The following is a description of a gene set: Human Gene Set: HP_ABNORMALITY_OF_PRENATAL_DEVELOPMENT_OR_BIRTH Abnormality of prenatal development or birth species: Homo sapiens An abnormality of the fetus or the birth of the fetus, excluding structural abnormalities., and this is the list of marker genes: DHCR7, CC2D2A, BUB1, BUB3, PLPBP, RAC2, CLCNKA, SHOC2 (SHOC2 leucine rich repeat scaffold protein), NIPBL, LAGE3, IFIH1, SMC3, TCTN1, LMNA, KIAA0586, WNT9B, SHPK, SMO, PPP1R13L, PUF60, ARSB, TSHR, ITGA8, EPB41, TCF4 (transcription factor 4), NDUFB10, PEX6, GATA6, RSPRY1, CERT1, COL1A1, SMC1A, ANO1, LAMB2, MDM2, OPA1, CAPRIN1, LZTR1, AARS1, DOHH, SNRPN (NCBI Gene Id 6638), GRIN2D, SPTA1, STK11 (serine/threonine kinase 11), RBM10, FGFR1, RPL8, NUP107, CELF2, NDUFS6, CFH, FAS, RPS19 (ribosomal protein S19), CTCF, ABCB11 (NCBI Gene Id 8647), CDKN2A, STOX1, PTPN11, DNMT3A, LBR, TAF6 (NCBI Gene Id 6878), RAG2, B4GALT1, MYLK, GABRG2, POLR2A, CALM2, SNTA1, DCLRE1C, RAD51, DBR1, CNTNAP1, ACTL6B, SEMA3D, EXTL3, GTF2IRD1, GFPT1, IFT80, DDX6, BUB1B, PLVAP, NOTCH1, HOXD13, GTF2I, PEX16, BSND, ACTA1, HPS6, NAA10, KCNA2, COL5A1, MYCN, NDUFS8, FZD4, NCF1, NDUFV2, TFAM, GBE1, FANCL, CFL2, DST, SIX3, UQCRFS1, FANCF, FARSB, DPF2, SLC25A1, B3GLCT, ZBTB42, COX15, NALCN, EBF3, HSPG2, MCTP2, TRIP4, NRCAM, MRPS22, CDC42BPB, DLL4, ASH1L, FERMT1, MPLKIP, ATP6V1A, HCN1, PMM2, ERBB3, TSEN2, DPYSL5, CDK13, ARSL, NDUFS1, RRAS, CLCN3, KLHL40, KRAS, DNM1, CHRNG, KCNJ1, TRAIP, PRMT7, TBX4, GBA1, MCM10, CYFIP2, PPM1B, CNTN1, ZIC3, SKIC3, OSTM1, CHRND, SOX9, CRKL, FLII, RNF113A, RPS17, AP1S2, HIC1, SNUPN, VPS35L (VPS35 endosomal protein sorting factor like), RPGRIP1L, ALG12, PGAP2, MYMK, TRAK1, VPS37D, ITGA7, PLEC, RERE, ATP6V1B2, GATA1, EOGT, GATB, PARS2, ABCD1, PCDH12, ERGIC1, SCN4A (NCBI Gene Id 6329), ARPC5, SLC25A26, KANSL1, FGFR3, ANK2, KIF20A, KIF14, SLC17A5, SNORD116-1, AMER1, ASCC1, F8, DONSON, GPKOW, USP7, DEF6, DEAF1, PEX11B, CARS2 (cysteinyl-tRNA synthetase 2, mitochondrial), LTBP3, CBL (Cbl proto-oncogene), RPL11, CEP290, SMN1, DYNC2H1, FBXO28, CAPNS1, TRIM37, FOXF1, FBXO43, ZIC2, DHPS, RPL31, GABRB2, ITPR1, ATP7A, SCN8A, NDUFA11, IPO8, TMEM126B (NCBI Gene Id 95018), GYPC, SON, MT-ND3 (NCBI Gene Id 4537), CNOT1, NRTN, GON7, SCN10A, TOP6BL, SLC25A24, RASA2, SOS2, FDXR, NEK8, PHIP, SFTPC, RPS15A (ribosomal protein S15a), SLC3A1, FH, BCR, NDUFAF3, COL6A2, CLCN7, EBP (EBP cholestenol delta-isomerase), GRN, CHAT, ESAM, COL11A1, MGAT2, NDUFV1, WDR62, TMEM107, PADI6, TMEM67, RAB34, INPPL1, SCN4B, PEX26, METTL27, PTRH2, FKBP14, COX11, REN, SLC16A2, DNM2, COG8, NEU1, SFTPB, SMARCAL1, TMCO1, AKT2, ALG8, CYP11B1, NSD2, CD96, SLC9A3, GRIP1, RAI1, ADAT3, CCDC47, SCN5A, GTF2IRD2, PSAT1, PTPN23, MT-ND1, PAICS, ERCC2, DHDDS, HS2ST1, CALM1, RPL18, HSPA9, PACS1, NUBPL, YWHAE, COL6A1 (NCBI Gene Id 1291), TP53RK, ALG1, SELENON, DALRD3, KIT, HACD1, KCNC2, ZSWIM6, CREBBP, UBE2A, H19, PTCD3, NUP88, SQSTM1, TBX5 (T-box transcription factor 5), TBC1D24, PRPS1, FANCM, RPL35, NECTIN1, MRPS16, PIGY, SFXN4, SEMA3C, NLRP7, RTL1, RPS27, TMEM237, CCBE1, SPOP, NDP, IGHMBP2, CHEK1, STAG1, GALK1, TRPV4, UNC45B, TREM2, DPM2, CDKN1C, QRICH1, GNPTAB, MTM1, LMOD1, RPL26, CACNA2D1, RBCK1, MAGEL2, PREPL, NDUFAF1, RALGAPA1, MAMLD1, HBB (NCBI Gene Id 3043), CLCNKB, SLC6A5, ITGA2, NDUFS4, PEX10, SV2A, SCN3A (NCBI Gene Id 6328), MRAS, IGF2, NDUFB3, NUP133, GREB1L, MECOM, HNRNPK, COL5A2, RPL9, MADD, MYH3, HBA2, EIF5A, WASHC5, VPS33B, PEX3, TMEM70, KIDINS220, PIGQ, GNB2, AFF2, FLVCR2, PSEN1, ERCC4, RPL5, KCNE1, KRT1, POLR3A, SOX18, NPHP3, SCYL2, LETM1, RAPSN, MAGED2, NPC1, ALX4, SZT2, SPINT2, SLC35D1, SYT2, KBTBD13, MAP3K7, COL6A3, TP53, WNT4, REC114, HYMAI, WNT3, POMP, CRELD1, NDUFAF2, TCTN2, JUP, ADAMTS2, CYP11B2, ERBB2, MYL9, COL3A1, EEF1A2, NDUFB11, EMC10, ATAD3A, CHRNE, HIRA, FANCB, PEX5, DOK7, MDFIC (MyoD family inhibitor domain containing), CRPPA, FBXL4, B9D1 (NCBI Gene Id 27077), COL2A1, TP63, ABCA3, THSD1, DSP, SPTBN1, ATP1A3, TRIP13, COASY, AXIN1, VPS13B, XRCC2, MKS1, HNF1B, TPM3 (NCBI Gene Id 91191), RFC2, ALG14, SARS2, TRIP11, RYR1, GP1BA, STX5, PRRX1, SUFU, SEC24D, EDN3, MYPN, MAX, ALPK3, GRM7 (NCBI Gene Id 2917), MYT1L, QRSL1, MAPK1, ALDH1A2, RHD, ASNS, SMARCD2, PIEZO1, KDM3B, ZFP36L2 (ZFP36 ring finger protein like 2), SLC2A1, TSEN54, RNU4ATAC, COL12A1, DYNC2LI1, SNRPB, MTHFS, PIGV, RPL35A, MUSK, MT-ND2, YWHAG, PEX19, HDAC8, FANCA, SLC26A3, CRIPTO, GTF2E2, SEC61A1, CA2, ALB, ROBO1, SLC30A9 (NCBI Gene Id 10463), CPLX1, DZIP1L, TAF1, PHACTR1 (NCBI Gene Id 81705), OFD1, SF3B4, CALM3, RFWD3, MYD88, SPRED2, B9D2, CORIN, CAMKMT, FANCG, LYN, TOR1A, ABCA12 (ATP binding cassette subfamily A member 12), UBE2T, ASXL2 (NCBI Gene Id 55252), FANCC, NOS1AP, CDAN1, FLI1, AGT, ECE1, SOS1, TBL2, CILK1, GLB1, TPRKB, GPC3, TXNDC15, CHST3, RNU4-2, PAK2, LHX1, DNA2, SKIC2, MTMR14, EFEMP2, FBLN5 (fibulin 5), RPS7, THOC2 (NCBI Gene Id 57187), BICD2, NDUFS2, SLC12A1, FOXG1, SLC25A12, KCNJ6, GLRB, DYNC2I2, FASLG, IRF6, CDON, INVS, IL2RG, WNT7A, FGF20, KCNB1, RRAS2, PHGDH, RBPJ, VAMP1, ESCO2, ACE, FANCE, WDR81, BTG4, PACS2, FOXRED1, PIK3CA, PAX2, ABCC6, CLTC, DCLRE1B, LRP5, NTRK2, FAT4, PWAR1, NSD1, DTYMK, CEP57, TPM2, LEMD2, ITGA2B, KCNQ1, MMACHC, IL1RN, FUT8, STS, LAMA5, DISP1, MTO1, COPB2, AIMP1, TPI1, NLRP3, CLIP2, CHUK, ACTB, CLTCL1, RPL27, WARS2, BCL10, MAD2L2, NEXMIF, CSNK2A1, FGFR2, RAD51C, PEX2, TGM1, PLAGL1, PIGA, CRTAP, GATC, FOXE1, GP1BB, LIG4, PDHA1, GLDN, ADCY6, SMPD4, EXT2, TSR2, INTS11, BRAF, GLI3, NDUFA6, SCN1A, WBP4, FRA10AC1, TNNC2, IL7R, SLC5A7, TWIST2, PEX14, TLK2, RAF1 (NCBI Gene Id 5894), UBA1, OTUD5, MSX1, RAD21 (NCBI Gene Id 5885), PPP1CB, NDUFS7, SMG9, PAFAH1B1, ERF, KLHL41, RAC1, PLD1, TIMMDC1, UROS, INSR, ALDH7A1, RPS29, AVPR2, RNF31, DIS3L2, TRPV3, PIGS, RIPK4, NAA20, SLC13A5, CD46, CNKSR2, SLC31A1, VANGL2, MAPT, ZC4H2, CASP10, TSFM, MYF6, EIF4H, MCM4, PIGG, NEK1, SIN3A, GGPS1, COL1A2, LTBP4, LORICRIN, STX1A, RRAGC, CHEK2, IL2RB, HSD17B4, RIT1, YARS1, DNAJC30, DMPK, SOX17, CAV3, ELN, EXOSC9, NDN, TBCD, DOCK6, MEGF10, SLC18A3, HYLS1, MKRN3, WT1, ZBTB18, COMT, ITGB4, SYNE1, KCNE2, OCA2, FLG, PWRN1, RAP1B, RPS24, ALPL, KIF26A, TAOK1, PLAA, MAFB, RMRP, CALCRL, LIFR, DUOX2, GJB2, F2, RHCE, GABRA5, TARS1, CHRNA1, BNC2, ODC1, KANK2, RPGRIP1, ACY1, VCP, SMARCAD1, FXR1, ZFX, OTX2, SPTB, TBX1, ATP6V0A1, ITGB3, AGTR1, NDUFAF5, SLC25A46, BMPER, CRLS1, RYR3, C1QC, NEB, PEX12, FZR1, IBA57, DPH5, RPL10, SNORD115-1, COL13A1, KCNQ5, NFASC, CTBP1, IARS2 (NCBI Gene Id 55699), SLC26A2, PDX1, SYNJ1, ATP6V1E1, PLOD1, SEC24C, GLE1, TALDO1, NUP188, BUD23, GPC6, ATP1A2, NDUFS3, CCDC174, IARS1, SCARF2, SYNGAP1, VARS1, BRIP1, CACNA1C, TWIST1, TMEM106B, AP3B2, SLC27A4, FLT4, SLC6A9, GLI2, WDR35, ERCC5, MYH7, IGF1 (NCBI Gene Id 3479), RPS26, UROD, CHMP2B, C1QBP, COQ7, FRAS1, BRCA1, EGFR, FGF12, ARHGAP31, FANCD2, NDUFB9, CHD8, DYRK1A, DPAGT1, IQCN, TRPV6, KCNQ1OT1 (KCNQ1 opposite strand/antisense transcript 1), RAG1, TRAF7, ITGA6, SLX4, IL6ST, PGAP3, LONP1, DYNC2I1, ARVCF, CSPP1, CLPB, RPS28, HERC2, CPT2, CACNA1A, UBA5, PIGO, NUS1, SREBF1, FCSK, FILIP1, ZMPSTE24, ADNP, GABRA2, H4C3, EDNRB, MEI1, RET, POR, MED12, COL11A2, SLC35A2, FREM2, CCDC22 (NCBI Gene Id 28952), SLC38A3, MYO9A, PIGL (NCBI Gene Id 9487), MEG3, BAZ1B, LRPPRC (NCBI Gene Id 10303), KIF5C, RPS20, RASA1, YRDC, NDUFAF4, KMT2D, ERCC3, LMOD3, MYL2, NDUFAF8, WWOX, AKAP9, LIMK1, FLNB, ATP6V0A2, NEK9 (NCBI Gene Id 91754), PIGW, RPL15, CHRM3 (NCBI Gene Id 654136), CAMK2B, PEX1, ADGRG6, CFI, ASAH1, CDK19, GMPPB, PNPO, TTC7A (tetratricopeptide repeat domain 7A), NPAP1 (NCBI Gene Id 23742), TRAPPC12, GFRA1, ABCB4, MAP2K1 (mitogen-activated protein kinase kinase 1), SLC1A2, FCGR3B, IFT56, MAP2K2, AGGF1, CPSF3, CRB2, RSPO2, RNF2, LDHA, KHDC3L, HRAS, COX14, GUSB, JMJD1C, HMGA2, OSGEP, SHH, ZNF699 (zinc finger protein 699, NCBI Gene Id 374879), TCTN3, F7, TUBA1A, PBX1, AHCY, COQ4, GABBR2, UBAP2L, CTSA (cathepsin A), MYL1, NR1H4, TMEM231, TAPT1, ADA2, RPS10, FBN1, FGF8, PIGN, SOD1, ATN1, NDUFA10, SATB1, PAX7, DOCK11, PTCH1, HELLPAR, NECAP1, UQCC2, ATP8B1, AGTPBP1, MYL11, CACNA1D (NCBI Gene Id 776), EPHB4, ADARB1, NDUFA1, EFNB1, ADA, RMND1, WDR4, TRDN, B3GALT6, AMMECR1, TMEM216, IQSEC2, HLCS (holocarboxylase synthetase), ABCD4, KIF21A, BIN1, MYOD1, SERPINE1 (serpin family E member 1), PCGF2, PKHD1, EP300, PALB2, CHD7, COG5, LGI4, GTF2H5 (NCBI Gene Id 404672), GJA1, DNM1L (NCBI Gene Id 692222), GOSR2, CACNA1B, FOXH1, RREB1, CD109, KAT6B, CLXN, IKZF1, FGF13, HBA1, DLL1, SERPINH1, AGRN, PHOX2B, PEX13, TMEM270, PRKAG2, FARSA, UFD1, FOXC2, ITGB2, NODAL, ACTG2, NSF, TGIF1, MPZ, PPP3CA, CSGALNACT1, BRD4, GDNF, F13A1, MAP3K20, HEATR3, PI4KA, MTHFR, SOX10, COL25A1, ADAMTS3, FIG4, SHQ1, BRCA2, HADHA, PLAG1 (NCBI Gene Id 7996), ASCL1, FGFRL1, PRUNE1, PTH1R, SLC25A19, ASXL3, NDUFB7 (NADH:ubiquinone oxidoreductase subunit B7), STRADA, NRAS, KIF7, KDM6A, RHAG, TBCK, FANCI, ALG9 (ALG9 alpha-1,2-mannosyltransferase), ORC1, FKBP6, SEMA3E, CEP55, SPEN, SNAP25, PRDM13, USP18, GPC4, VAC14, GAS1, KCNH2, SPECC1L, DLK1, F13B, NELFA, GAA, KLF1, ENPP1, AQP2, WDR73, NPC2, G6PC3, SETD1A, CYP11A1, FLT1, CARS1, LARS2, MOGS (NCBI Gene Id 7841), ASXL1, MYH11 (myosin heavy chain 11), PKLR, STAT2, USP9X, MBTPS2, KCNJ5